Given this list of marker genes NHS, TARS1, ERCC3, SEC31A, AGK, RPL5, TSR2, COL18A1, RPL9, RAB18, RPS26 (NCBI Gene Id 6231), AARS1, ATAD3A, PSMC3, PAX6, GTF2E2, RPS29, OCRL, DPAGT1, ERCC2, ELN, MT-TL1, VHL, ERCC6, FAM111A, MT-CO1, PEX11B, BCOR, CRYBB1, RIC1, MT-TW, BFSP2, MT-TV, RPL8, ETFDH, PEX5, RPL31, CRYBA2, MT-TC, COL4A5, FBLN5, MT-TQ, RET, CTDP1, CHD6, MSMO1, MT-TS2, EPG5, SIL1, ARPC4, RPL35, MT-CO3, RAB3GAP1, PIK3C2A, RPL27, RPS7, MIR204, TMEM127, ERCC1, MT-ND1, ATOH7, HYCC1, MAF (MAF bZIP transcription factor), LARGE1, TELO2, RPS20, ABCA2, LMNA, MAFA, CRYBB2, MAX, GFER, MT-TK, SMC5, MT-ND6, PNPT1, RPL11, CRYBB3, KMT2C, SLC33A1, ENTPD1, RPS17, CARS1, RPS19, PHGDH, RPS15A, NEU1, PITX3, CRYBA1, SIPA1L3, RAB3GAP2, BMP4, RPL35A, RPS28, CRYGD, RPS10, PIGY, CRYAA, MT-CO2, POMT1, ETFB, IARS2, VPS4A, PEX7, GATA1, NAA60, RNF113A, GTF2H5, SNUPN, ALDH18A1, KCTD1, MED25, ETFA, EPHA2, FZD4, BEST1, MT-TF, GCNT2, COL4A1, RPL18, RPL26, RECQL4, DOCK6, ADA2, RPL15, CRYGB, RPS24, RPS27, UBE2A, TBC1D20, HEATR3, LONP1, NUP188, NDP, CRYGC, EHMT1, ANAPC1, HSPG2, KCNA4, ERCC8, KANSL1, CAV1, MPLKIP, MT-ND5, MT-CYB, LSS, TKT, IDH1, HMX1, CRYAB, here is a description of the gene set: Human Gene Set: HP_DEVELOPMENTAL_CATARACT A cataract that occurs congenitally as the result of a developmental defect, in contrast to the majority of cataracts that occur in adulthood as the result of degenerative changes of the lens. studied in species Homo sapiens Developmental cataract